The following is a description of a gene set: Transforming growth factor-beta1 (TGF-beta) regulates cellular functions like proliferation, differentiation, and apoptosis. On the cell surface, TGF-beta binds to receptor complexes consisting of TGF-beta receptor type II (TbetaRII) and activin-like kinase receptor-5 (Alk5), and the downstream signaling is transduced by Smad and MAPK proteins. Recent data have shown that alternative receptor combinations aside from the classical pairing of TbetaRII/Alk5 can be relevant for TGF-beta signaling. We have screened for alternative receptors for TGF-beta and also for gene targets of TGF-beta signaling, by performing functional assays and microarray analysis in murine embryonic fibroblast (MEF) cell lines lacking Alk5. Data from TGF-beta-stimulated Alk5(-/-) cells show them to be completely unaffected by TGF-beta. Additionally, 465 downstream targets of Alk5 signaling were identified when comparing Alk5(-/-) or TGF-beta-stimulated Alk5(+/+) MEFs with unstimulated Alk5(+/+) cells. Our results demonstrate that, in MEFs, TGF-beta signals exclusively through complexes involving Alk5, and give insight to its downstream effector genes. studied in species Mus musculus from publication Karlsson G, Liu Y, Larsson J, Goumans MJ, Lee JS, Thorgeirsson SS, Ringnér M, Karlsson S (PMID 15769904) Genes down-regulated by TGFB1 in MEF cells (embryonic fibroblast) via TGFB1R. Mouse Gene Set: KARLSSON_TGFB1_TARGETS_DN, and this is the list of marker genes: H2az2, Mtus1, Dusp8, Zfp36l1, Man2b1, Mgst1, Efna5, Npnt, Tbcel, Bet1l, Adipor2, Alad, Iah1, Txndc12, Tmbim6, Pard6b, Npc2, Gaa, Rgs10, Add3, Leprot, Timp2, Agap1, Neat1 (nuclear paraspeckle assembly transcript 1 (non-protein coding)), Gas1, Ado, Upf3b, Pnrc1, Sike1, Tmem176b, Acbd4, Zfp780b, Maged1, Ndfip1, Ap3b1, Ctsb, Gsn, Dbi, F11r, Bnip3l, Stard4, Fut8, Slc39a10, Nudt14, Mgat3, Ccdc80, Mat2b, Ctnnbip1, Wwtr1, Crip1, Dnmt3a, Emc2, Hmgn2 (NCBI Gene Id 15331), Wars1, Plat, Mllt6, Wbp2, Lama5, Tmem132a, Cd2ap, Wt1, Bsg, Dusp18, Actn1, Schip1, Stmn1, Syne2, Nid2, Slc48a1, Dcn, Maf1, Tecr, Paip2, Col6a1 (collagen, type VI, alpha 1, NCBI Gene Id 12833), Ctsa, Bloc1s1, Grina, Dctn6, Nrep, Kmt2e, Cdkn2c, Fth1, Ephx1 (NCBI Gene Id 98277), Id3, Usp25, Ccnl2, Alcam, Kcnd3, Rin2 (Ras and Rab interactor 2), Enpp4, Arnt, Trim24, Dnaja1, Gstm2, Anapc1, Chp1, Pcna, Pkhd1l1, Isyna1, Syt11, Ezr, Slc44a1, Ccni, Fam234a, Id2, Gdi1, Azi2, Zfp395, Igfbp4, Sh3bgrl, Plxnb2, Golm1, Pdgfra, Slc12a9, Xiap, Tnip1, Ing4, Net1, Smarca2, Shroom3, H1f0 (H1.0 linker histone), Gabarapl1, Osbpl9, Gsta4, Bbx, Polr2a, Gria2, Nherf1, Cxadr, Slc16a1, Twsg1, Ptpn13, Grn, Dcaf8, Scp2, Gstm1, Bend4, Ctsz (NCBI Gene Id 99199), Maoa, Adam10, Nfia, Tle5, Pik3r1, Sfrp2, Mxd4, Kcnc4, Copz2, Glul, Stat3, Lamp2, Nod1, Tpi1, Atp6v1f, Ssx2ip, Smpdl3b, Tbc1d2b, Ctdsp2, Ildr2, Tpmt, Nlgn2, Nbr1, Vamp8, S100pbp, Oip5os1, Id1, Serinc3 (serine incorporator 3), Tnrc6b, Sesn1, Psme2, Cntnap1, Tmem59, Dag1, Tmem98, Tlcd3a, Rgs8, Rasl11a, Acaa2, Dennd4c, B3gat1, Tgm2, Ly6e, Gata6, C4b, Dab2, Met, Atp5if1, Rsrp1, Rnf11 (NCBI Gene Id 29864), Tmc5, Slc10a6, Supt6, Stmn2, Appl2, Nme1, Cst3, Itm2b, Gabarap